The following is a description of a gene set: RNA polymerase II transcribes snRNA genes species: Mus musculus Mouse Gene Set: REACTOME_RNA_POLYMERASE_II_TRANSCRIBES_SNRNA_GENES, and this is the list of marker genes: Taf13, Ell3, Polr2h, Cdk9, Taf9, Pou2f2, Ints3, Polr2e, Srrt, Gtf2e2, Ints12, Taf6, Ints5, Ccnt2, Ell2, Rprd2, Gtf2a1, Phax, Ncbp1, Cdk7, Polr2c, Polr2b, Gtf2e1, Rprd1a, Polr2k, Sp1, Ncbp2, Snapc4, Gtf2b, Ccnk, Ints1, Pou2f1, Ints7, Taf5, Ak6, Ints11, Snapc1, Gtf2f2 (NCBI Gene Id 68705), Taf8, Ints2, Polr2g, Ints14, Supt4a, Ints13, Supt5, Ints8, Snapc5, Polr2a, Rpap2, Ints10, Pcf11, Rprd1b, Ssu72, Ccnt1, Polr2f (polymerase (RNA) II (DNA directed) polypeptide F), Ints9, Ints6, Ints4, Nabp2, Gtf2f1, Gtf2a2, Snapc2 (small nuclear RNA activating complex, polypeptide 2), Tbp, Ell, Polr2d, Taf11, Zc3h8, Ice2, Ice1, Nabp1, Polr2l, Snapc3, Polr2i